Given this list of marker genes KIF5B, NLGN2, PRKCE, NLGN1, NRXN1 (neurexin 1), TAC1, ZDHHC3, ADORA2A, ZDHHC12, TACR1, HAP1, CA2, NALCN, NPS, ADRA1A, CA7, here is a description of the gene set: Human Gene Set: GOBP_POSITIVE_REGULATION_OF_SYNAPTIC_TRANSMISSION_GABAERGIC Any process that activates, maintains or increases the frequency, rate or extent of GABAergic synaptic transmission, the process of communication from a neuron to another neuron across a synapse using the neurotransmitter gamma-aminobutyric acid (GABA). studied in species Homo sapiens